The following is a description of a gene set: Mouse Gene Set: WP_ALPHA_6_BETA_4_INTEGRIN_SIGNALING_PATHWAY studied in species Mus musculus Alpha 6 beta 4 integrin signaling pathway, and this is the list of marker genes: Rtkn, Grb2, Eif4ebp1, Fyn, Cdkn1a, Pik3cd, Lamb3, Cd151, Ar, Pik3cg, Prkca, Lama1, Vim, Itga6, Prkcd, Lamb1, Ywhae, Smad2, Bad, Mmp7 (matrix metallopeptidase 7), Itgb4, Irs1, Dst, Col17a1, Abl1, Rac1, Erbin, Ywhah, Eif6, Eif4e, Clca1, Lamc1, Ntn1, Plec, Shc1, Smad3, Erbb2, Met, Lama3, Pik3r1, Lama2, Rhoa, Lamb2, Src, Mtor, Yes1, Casp3, Dsp, Trp73, Rpsa, Ywhaz, Egfr, Lamc2, Lama5, Pik3r3, Ywhab, Pik3r2, Akt1, Clca2, Pik3ca, Irs2, Pak1, Pik3cb, Mst1r, Sfn, Ptk2 (PTK2 protein tyrosine kinase 2)